The following is a description of a gene set: Mouse Gene Set: MIR_363_5P studied in species Mus musculus Genes predicted to be targets of miRBase v22 microRNA mmu_miR_363_5p in miRDB v6.0 with MirTarget v4 prediction scores > 80 (high confidence targets). from publication Chen Y, Wang X (PMID 31504780), and this is the list of marker genes: Phf20, Ikbkg, Cenpm, Mmp28, Fam81a, Nmur2, Knop1, Elovl4, Ephb1 (Eph receptor B1), Bche, Yif1a, Rab10, Akap8, Arhgef37, Dipk2a, Acer1, Nifk, Cyfip2, Itsn1, Eomes, Slc26a9, Plcg2, Asic1, Chd3, Adamts9, Dap3, Srebf2, Fst, Sipa1l1, Ubap2, Zfp664, Kcnj4, Pi4kb, Rgs18, Gm3985, Rasgrp4, Kcnt2, Atxn7, Mfsd8